Given this list of marker genes FNDC4, KYNU, XBP1, RASGRF2, EZHIP, RPL37, IL5RA, ACSL5, SPIC, ZSCAN29, LY6D, PEPD, IL9R (NCBI Gene Id 3581), ACAT2, MED15, RAB21, PDCD6IP, APC, KMO, GNA13, MCL1, ZBTB14, MTMR14, PARP14, ITGB7, NFIL3, NCBP1, GPD2, MST1, TRAM1 (NCBI Gene Id 23471), CCK, FCGRT, GZMA, NDC80, VPREB3, CARF, NUCKS1, FAM156A, BOLA1, FGF7, ST8SIA4, ELL2, TMSB4X, BRAF, TBC1D8B, CRYBG1, PNOC, FAM167A, CTSS, RCOR1, WNT3, SNX30, CASP8, HSD11B1, ARFGEF2, UBA6 (ubiquitin like modifier activating enzyme 6), SYNE2 (spectrin repeat containing nuclear envelope protein 2), NEU3, ADGRL2, GPR174, KLF8, PRPF6, MTPN, LRRK2, STARD3NL, COPS7A, LRCH3 (NCBI Gene Id 84859), CHCHD2, GSTO1, CCDC97, NOP53, YAF2, TENT5A, MYF5, CDYL, COL13A1, MRPL23, ABCA6 (ATP binding cassette subfamily A member 6), BAX, ATP10D, RHOA, ADAM19, PARP3 (poly(ADP-ribose) polymerase family member 3), PFDN6, NDRG3, LCN2, BCL6, ISY1, PHF5A (PHD finger protein 5A), PSMB1, FHIP2A, TRIM34, NAB1, FCHSD2, NCS1, ZBTB24, LYRM1, ITSN1, RND2, TRIP10, ATP2B1, RERE, PDIA6, INSYN2B, KLRD1, TMEM65, PSMB8, SEMA5A, CDON, NUP133, EP300, CRYBB3, C1QTNF12, BTRC, UNC93B1, PYHIN1, PDE4B, ACOT9, GPR12, ELMO2 (engulfment and cell motility 2), SKAP2, CEACAM1, SMC2, MRPL44, KDSR, CTSA, MOB1B, GPR141, MDC1, HRH2, SMCHD1, SLC30A4, N4BP2L2, RAMP1, PHYH, RPS18, CREM, UBQLN2, RNASEH2B, DYNLL2, KLF3, SFMBT1 (NCBI Gene Id 51460), TACSTD2, PRKAG1, FCMR, POLR3B, CYP27A1, TIMM17B, CD55, KBTBD3, PANK2, FTO, TMEM69 (NCBI Gene Id 51249), BCL9, LGALS8, TMEM229B, IL2RG, NMT2, MAZ, SIKE1, here is a description of the gene set: Human Gene Set: GSE25677_MPL_VS_MPL_AND_R848_STIM_BCELL_UP Many successful vaccines induce persistent antibody responses that can last a lifetime. The mechanisms by which they do so remain unclear, but emerging evidence suggests that activate dendritic cells (DCs) via Toll-like receptors (TLRs). For example, the yellow fever vaccine YF-17D, one of the most successful empiric vaccines ever developed, activates DCs via multiple TLRs to stimulate pro-inflammatory cytokines. Triggering specific combinations of TLRs in DCs can induce synergistic production of cytokines, which results in enhanced T cell responses, but its impact on antibody responses remain unknown. Learning the critical parameters of innate immunity that programs such antibody responses remains a major challenge in vaccinology. We demonstrated that immunization of mice with synthetic nanoparticles containing antigens plus Toll-like receptor (TLR) ligands 4 (MPL) + 7 (R837) induces synergistic increases in antigen-specific, neutralizing antibodies compared to immunization with a single TLR ligand. To determine whether there was any early programming of B cells, we isolated isotype switched, TCRbeta-CD11b-CD19+IgD-IgG+ B cells by FACS at 7 days post immunization with nanoparticles containing various adjuvants plus OVA, and performed microarray analyses to assess their molecular signatures. Genes up-regulated in B lymphocytes immunized with: monophosphoryl lipid A (MPL) versus MPL and imiquimod. from publication Kasturi SP, Skountzou I, Albrecht RA, Koutsonanos D, Hua T, Nakaya HI, Ravindran R, Stewart S, Alam M, Kwissa M, Villinger F, Murthy N, Steel J, Jacob J, Hogan RJ, García-Sastre A, Compans R, Pulendran B (PMID 21350488) studied in species Homo sapiens